Given this list of marker genes Knl1, Rrn3, Rps7, Marchf7, Mdm2, Mif, Sh3glb1 (NCBI Gene Id 99782), Ankrd2, Myc, Ubb, Triap1, Bdkrb2, Mdm4, Pttg1ip, Hnrnpk, Muc1, Trp73, Bcl2l12, Atad5, Tifab, Cd44, Cep63, Sirt1, Msx1, Steap3, Cd74, Trp53, Prkn, Ell3, Bmyc (brain expressed myelocytomatosis oncogene), Rpl26, Kdm1a, Usp15, Rrm2b, Armc10 (NCBI Gene Id 67211), Zfp385a, here is a description of the gene set: Any process that modulates the frequency, rate or extent of intrinsic apoptotic signaling pathway by p53 class mediator. species: Mus musculus Mouse Gene Set: GOBP_REGULATION_OF_INTRINSIC_APOPTOTIC_SIGNALING_PATHWAY_BY_P53_CLASS_MEDIATOR